The following is a description of a gene set: Human Gene Set: HP_APLASIA_OF_THE_BLADDER Aplasia (absence) of the urinary bladder. Aplasia of the bladder studied in species Homo sapiens, and this is the list of marker genes: FREM2, ITGB4, PLEC, ITGA6, CC2D2A